Given this list of marker genes H2ac7, H2ac23, Tada2a, Mbip, H2ac10, H2bc24, Akap8l, H2ac15, H3c7, H2aj, H3c6, Setd1b, H3c4, Wdr82, Men1, H2ac4, H3c13, Kat8, H2bc22, Kat14, H4c2, H4c12, H2bc6, H2bc4, H3c14, Kansl2, H3c10, H3f3a, H2ac6, Hcfc1, H4c3, Cxxc1, H2bc8, Rxra, H4c1, H3f3b, H3c1, Tada3, H4c8, Kmt2a, H2ab2, H3c15, H2ab3, Sgf29, H4c4, H2ac13, Bod1l, Ncor2, H4c18, Paxip1, H4c9, Dr1, H2ax (NCBI Gene Id 15270), Kmt2b, H2ac19, H2bc1, Tbl1xr1, Hdac3, Tbl1x, H2ac18, H4c17, H2ac8 (NCBI Gene Id 319166), Kat2a, H2ac20, Kmt2d, H3c3, Phf20, H2bc11, H4c11, H3c11, H2ac22 (NCBI Gene Id 319170), H2bc3, H2bc23, Kat2b, Mcrs1, H2ac24, H3c2, Tasp1, Kansl1, H2bc21 (H2B clustered histone 21), H2az2, Kansl3, Hcfc2, Abl1, H2ab1, Rbbp5, H2ac11, H2bc26 (NCBI Gene Id 97778), H2bc7, H3c8 (NCBI Gene Id 97908), Zzz3, H4c16, Phf20l1, H4c14, H2ac12, H2bc15, H2bc14, Psip1, Ash2l, H2bc13, H4c6, H2bc12, Setd1a, Pagr1a, Gps2, Kdm6a, Yeats2, H2bc9, Ogt, Wdr5, here is a description of the gene set: Epigenetic regulation by WDR5-containing histone modifying complexes Mouse Gene Set: REACTOME_EPIGENETIC_REGULATION_BY_WDR5_CONTAINING_HISTONE_MODIFYING_COMPLEXES species: Mus musculus